Given this list of marker genes RGL1, LAIR2, NEU1, SUPV3L1, PPP1R15A, NUP153, PTP4A1, AK4, GPD2, SETX, SGMS1, PDIA3, MAP3K8, CDC27, PTK2B, GSAP, DNAJC13, NT5C2, PFDN1, ISCU, BST2, DUSP1, TARBP1, LPAR1, DLAT, PDHX (pyruvate dehydrogenase complex component X), USP8, SPP1, KIN, IFI27, CD164, KLF10 (NCBI Gene Id 7071), TMED5, PIGH, MYO1E, LIPA, SPG11, TGIF1, PDIA6, NDEL1, ADAR, COQ7, NDUFA6, R3HCC1L, N4BP1, PROCR, NDUFB5, MRPL12, CCL7, PDCD11, NCOA6, CTSL, FICD, LGALS3BP, ABRAXAS2, RPS6KB1, ATF5, LSS, TGM2, PHYH, PLSCR1, LRP2 (NCBI Gene Id 4036), IGHM, HTATIP2, CHAF1A, LIG4, HEXA, HSPB1, ISG15, PSMC3, CHMP2B, MRPL19, PRPF18, TCL1A, SLC25A13, VIM, SPINK1, SLC38A6, MTX2, UBE2M, STARD8 (NCBI Gene Id 9754), TFDP1, RARS1, LAMP2, TUBB2A, NFX1, DOCK10, GPR18, ARHGAP25, TOR1B, IRAK1, TBCC, MRPS11, PDE4DIP, RTCB, CASP5, BCAS2, FKBP15, ATOX1, CAPN2, HCCS, SMURF2, ARPC1A, ELF1 (E74 like ETS transcription factor 1), VRK2, CGRRF1, CD58, ADAMDEC1, SIK1, MTHFD1, OTUD4, GMFB, PSMA3, UBE2L3, RNF19B, ST3GAL5 (NCBI Gene Id 8869), TRIM21, IFI35, BRD2, TCEAL1, PSMD11, MAP3K4, IFITM3, ZBTB43, ST8SIA4, TOB1, MPP1, CD2AP, FNDC3A, VPS26C, RB1, DECR1, NAT1, CTSC, TSPYL5, SP100, ANXA1 (NCBI Gene Id 301), IFIT1, MAPK6, IFITM2, PPP2R2A, XRCC4, NUCB1, NPC1, ATG4A, ELL2, TIMM8A, METTL13, CGGBP1, ANXA4, MX1, DCTN6, PGGT1B, SP110, FXR1, BLOC1S1, CKB, SSB, LILRB4, GATAD1, FPR3, CSTF2, MED7, THBD, ATP6V1E1, CCDC86, LRRFIP1, NR1H3, MICB, MEF2A, BARD1, CREG1, TIMM17A, MX2, GNG11, CDV3, GRSF1, SLC30A1, BCL2L2, NUCB2, CD47, OASL, TDP2, BLZF1, IL1RN, CCL8, TDRD7, BLTP1, CPM, GUK1, STX3, LYSET, NSMAF, TRIP4, AGPS, FANCL (NCBI Gene Id 55120), RASGRP3, PSMB8, IRF2, CMTR1, here is a description of the gene set: from publication Suzuki K, Maruya M, Kawamoto S, Sitnik K, Kitamura H, Agace WW, Fagarasan S (PMID 20643338) Human Gene Set: GSE19401_UNSTIM_VS_PAM2CSK4_STIM_FOLLICULAR_DC_DN species: Homo sapiens Genes down-regulated in the in vitro follicular dendritic cells from peripheral lymph nodes: unstimulated versus Pam2CSK4 (96h). Germinal centers (GCs) are clusters of activated B cells built on stromal cells known as follicular dendritic cells (FDCs). In the Peyer’s patches (PPs), GCs are chronically induced by bacteria and are the major sites for generation of gut IgA immune responses. Whether FDCs directly contribute to the IgA production in PP GCs is unknown. To investigate the role FDCs in gut immune system, we examined comprehensive gene profiles of FDCs purified from PPs or perypheral lymph nodes (pLNs) with or without immunization. We also tried to reconstitute the PP FDC signature in vitro by pulsed or continuous stimulation of pLN FDCs through TLRs, RARs or simultaneously through TLRs and RARs.